Given this list of marker genes CSNK1G2, IFT88, CHN1, ATP13A3, FBXO21, CAMK1G, MPG, SLC16A5, SLC35E2B, DNASE1L1, MXD4, ACY1, FGF2, ADIRF, SLIT2, FILIP1L, SVIL, PTX3 (pentraxin 3), ATP2B4, COL1A2, ADH5, TRAM2, SERPINB6, STMN2, WNT5A, MACF1, THBS1, GJA1, ACADVL, PBX1, DHRS3, ADH1B, FABP3, LMNA, TSHB, TMEM187, PDCD4, TGFBR3, NRP1, ADH1A, DIP2C, CACNA1E, MT1H, KIAA0930, MAGI2, MAP2K6, PLEC, ID2, POLD2, TPM1, RUNX1, TMT1A, NDP, ROR2, AKR1C3, RBPMS, COL13A1, PDLIM7, COL1A1, ADAMTS2, CSH1, ANKRD1, NR1H3, COG4, DCLK1, CXCL9 (NCBI Gene Id 4283), APOBEC3C, FBXL2, SEMA5A, ZFP36L2, MT1B, UBE2C, ACAA2, GFAP, ANPEP, C14orf132, SEMA3A, AP4S1, MVD, GDF10, RHOBTB3, SERPINH1, NAAA, here is a description of the gene set: from publication Browne EP, Wing B, Coleman D, Shenk T (PMID 11711622) Human Gene Set: BROWNE_HCMV_INFECTION_16HR_DN The effect of human cytomegalovirus (HCMV) infection on cellular mRNA accumulation was analyzed by gene chip technology. During a 48-h time course after infection of human diploid fibroblasts, 1,425 cellular mRNAs were found to be up-regulated or down-regulated by threefold or greater in at least two consecutive time points. Several classes of genes were prominently affected, including interferon response genes, cell cycle regulators, apoptosis regulators, inflammatory pathway genes, and immune regulators. The number of mRNAs that were up-regulated or down-regulated were roughly equal over the complete time course. However, for the first 8 h after infection, the number of up-regulated mRNAs was significantly less than the number of down-regulated mRNAs. By analyzing the mRNA expression profile of cells infected in the presence of cycloheximide, it was found that a minimum of 25 mRNAs were modulated by HCMV in the absence of protein synthesis. These included mRNAs encoded by a small number of interferon-responsive genes, as well as beta interferon itself. Cellular mRNA levels in cytomegalovirus-infected cells were compared to the levels in cells infected with UV-inactivated virus. The inactivated virus caused the up-regulation of a much greater number of mRNAs, many of which encoded proteins with antiviral roles, such as interferon-responsive genes and proinflammatory cytokines. These data argue that one or more newly synthesized viral gene products block the induction of antiviral pathways that are triggered by HCMV binding and entry. Genes down-regulated in primary fibroblast cell culture after infection with HCMV (AD169 strain) at 16 h time point that were not down-regulated at the previous time point, 14 h. studied in species Homo sapiens